Given this list of marker genes IL12RB2, KLRC4-KLRK1, IGLL1, GPR68, GPA33, CCR7, RNU4-50P, CD19, SH2D2A, ADA, ZNF831, CD2, IL2RA, LINC01215, SKAP1, SCARNA21B, CRIP1, FCRL2, CLIC3, ERVH48-1, SLC22A9, PRTN3, SH2D1B, APOBEC3G, CD247, LTA (NCBI Gene Id 4049), PRF1, AOX2P, ENSG00000238390, FCRL6, HLA-F, SH2D4B, ICOS, TESPA1, VPREB3, S1PR5, NELL2, ENSG00000267568, FLT3LG, ACAP1, RAG2 (NCBI Gene Id 5897), CARMIL2, SCN3A, MT1X, TNIP3, CD79A, BACH2, TRBC2, PRR11-AS1, EOMES, SLAMF1, RPLP0P6, ZAP70, GOLGA7B, NKG7, TIGIT, ITK, FCRL3, CD8A, MS4A1, RASD1, FCRL5, STK17A, CD3E, TRD-AS1, TCF7, TRAPPC14, KLRC2, CCR6, S1PR4, RN7SL743P, MYO1G, ARPP21, SUN2, CCDC141, LINC00861, CR2, CNR2, TNFSF14, TNFRSF18, BCL11B, NCR1, GZMM, VPREB1, IL21R, TMIGD2, CD160, CTSW, ATP13A4, PLEKHF1, CXCR4, PTPRCAP, PLAAT4, FCMR, CD7, NCR3, IL2RB, KLRC1, ZNF101, C16orf54, RASGRP1, ZNF319, FOXP3, CD3D, RPL12P1, ISG20, GPR18, SIT1, TERT, SEPTIN1, NT5C3AP2, LINC01891, PBXIP1, TTN (titin), IGHD, POU2AF1, ENSG00000236935, LINC01934, PAX5 (paired box 5), LY9, DTHD1, LAX1, LCK, LRRN3, THEMIS, CST7, ANKRD44-AS1, EML2-AS1, ATP1A3, CD27, RHOH, GPR171, SH2D1A, GFI1, DNTT, TRAT1, NIBAN3, P2RX5, GZMA, SLFN12L, SCML4, MYOM2, LTB, RN7SL47P, CD5, DUSP2, RHOQ-AS1, IKZF3, BLK, PARD6A, RUNX3, LINC02481, TRDC, SHISAL2A, IFNG, RPSAP12, TCL1A, TBX21, DGKA, IFNG-AS1, KLC2-AS2, JAKMIP1, IL2RG, MATK, PYHIN1, SLAMF6, ENSG00000259097, KCNQ5, TKTL1, IGKC, PAX6, CD79B (CD79b molecule), KLRC3, BAK1, TNFRSF14-AS1, RAG1, BICDL1, THBS4-AS1, PTPN22, SATB1-AS1, SIRPG, LINC01588, PRKX-AS1, XCL1, GZMK, SLFN5, KLRF1 (killer cell lectin like receptor F1), LINC00426, LINC02562, KLRB1, CD52, SASH3, IL7R, RN7SL49P, CXCR5, FCRL1, LINC01550 (long intergenic non-protein coding RNA 1550), CHI3L2, AOX3P, SAMD3, DDTL, CRTAM, DOC2GP, CD3G, SEC1P, TNFSF4, DENND2D, P2RY10, HLA-DOB, CD69, RNU6-118P, here is a description of the gene set: Human Gene Set: DESCARTES_FETAL_KIDNEY_LYMPHOID_CELLS from publication Cao J, O'Day DR, Pliner HA, Kingsley PD, Deng M, Daza RM, Zager MA, Aldinger KA, Blecher-Gonen R, Zhang F, Spielmann M, Palis J, Doherty D, Steemers FJ, Glass IA, Trapnell C, Shendure J (PMID 33184181) Marker genes curated from the annotated cluster as represented in the Descartes Human Gene Expression During Development database. The gene expression program underlying the specification of human cell types is of fundamental interest. The study authors generated human cell atlases of gene expression and chromatin accessibility in fetal tissues. For gene expression, the study authors applied three-level combinatorial indexing to >110 samples representing 15 organs, ultimately profiling ~4 million single cells. The study authors leveraged the literature and other atlases to identify and annotate hundreds of cell types and subtypes, both within and across tissues. Our analyses focused on organ-specific specializations of broadly distributed cell types (such as blood, endothelial, and epithelial), sites of fetal erythropoiesis (which notably included the adrenal gland), and integration with mouse developmental atlases (such as conserved specification of blood cells). These data represent a rich resource for the exploration of in vivo human gene expression in diverse tissues and cell types. studied in species Homo sapiens